The following is a description of a gene set: species: Mus musculus Mouse Gene Set: GOBP_RESPONSE_TO_WORTMANNIN Any process that results in a change in state or activity of a cell or an organism (in terms of movement, secretion, enzyme production, gene expression, etc.) as a result of a wortmannin stimulus., and this is the list of marker genes: Cdc5lrt10, Cdc5lrt5, Cdc5lrt7, Cdc5lrt6, Cdc5lrt1, Cdc5l, Abcc2, Fgf2, Cdc5lrt9 (cell division cycle 5 like, retrotransposed 9), Cdc5lrt8, Cdc5lrt4